Given this list of marker genes Mkks, Mtor, Pyy, Cck, Gfral, Or4m1, Bbs2, Npy, Gcg, Ucn, Npff, Gdf15, Prkcg, Nenf, Nucb2 (nucleobindin 2), Lep, Mt3, Oprm1, Fbn1, Ghrl (ghrelin), Ghsr, Cartpt (NCBI Gene Id 27220), Spx, Ppara, Bbs4, here is a description of the gene set: Mouse Gene Set: GOBP_REGULATION_OF_RESPONSE_TO_FOOD Any process that modulates the frequency, rate or extent of a response to a food stimulus. studied in species Mus musculus